The following is a description of a gene set: studied in species Mus musculus The chemical reactions and pathways involving lauric acid, a fatty acid with the formula CH3(CH2)10COOH. Derived from vegetable sources. Mouse Gene Set: GOBP_LAURIC_ACID_METABOLIC_PROCESS, and this is the list of marker genes: Cyp4a12a (NCBI Gene Id 277753), Cyp4a14, Cyp4a30b, Cyp4a12b, Cyp4a29, Cyp4a10, Cyp4a32, Cyp4a31